The following is a description of a gene set: Reactome Pathway: Paracetamol ADME part of: Drug ADME studied in species Homo sapiens Paracetamol (APAP, aka acetaminophen or N-acetyl-p-aminophenol) is an analgesic drug used for to treat mild to moderate pain and as an antipyretic agent. It is one of the most widely used drugs in the world and is available alone or in combination with other drugs for pain relief, fever and allergy. It is thought to act through the inhibition of cyclooxygenases 1 and 2. Paracetamol is generally safe at therapeutic doses but in overdose cases, it causes mitochondrial dysfunction and centrilobular necrosis in the liver which can lead to death.<br><br>APAP has a high oral bioavailability (~88%), is well absorbed and reaches peak blood concentrations after 90 minutes after ingestion. APAP binds plasma proteins to a small extent and has a plasma half-life of 1.5-3 hours. Most of the drug is eliminated by glucuronidate and sulfate conjugation (~55% and ~30% respectively) in the liver or as unchanged drug (~5%). A small amount (5-15%) is oxidised to the reactive metabolite N-acetyl-para-benzoquinone imine (NAPQI). NAPQI is usually detoxified by binding to liver glutathione but in overdose cases, glutathione is depleted and NAPQI instead, binds to sulfhydryl groups on proteins, leading to liver damage. ABCC2, ABCC3, ABCC4 and ABCG2 transporters mediate the efflux of APAP metabolites out of cells (McGill & Jaeschke 2013)., and this is the list of marker genes: ACY1, ABCG2, ABCC3, SULT1A4, SULT2A1, NAT2, UGT2B15, ABCC4, SULT1A1, CNDP2, SULT1C4, SULT1E1, GGT7, NAT1, GSTT1, ABCC1, GGT1, UGT1A9, GSTP1, ABCC5, GGT3P, ABCC2, SULT1A3, CYP2E1, UGT1A6, GGT6, UGT1A1, GGT5, UGT1A10, GSTM1